Given this list of marker genes ITPKB, NME7, DLG1, DTYMK, IP6K2, UAP1, AK9, CMPK1, AK8, CARD11, LRGUK, NME3, AK1 (NCBI Gene Id 203), MAGI3, ITPKA, DLG2, PPIP5K1, CASK, NME1, CMPK2, ITPKC, TJP2, NME9, AK3, IP6K3, AK5, MPP1 (NCBI Gene Id 4354), NME2, AK4, AK7, AK2, NME4, AK6, NME6, NME2P1, PPIP5K2, IP6K1, GUK1, PMVK, NME5, here is a description of the gene set: studied in species Homo sapiens Human Gene Set: GOMF_PHOSPHOTRANSFERASE_ACTIVITY_PHOSPHATE_GROUP_AS_ACCEPTOR Catalysis of the transfer of a phosphorus-containing group from one compound (donor) to a phosphate group (acceptor).